Given this list of marker genes Ogdh, Dclk2, Atp7a, Plxna3, Foxg1, Atg7, Fgfr2, Scyl2, Dcx, Zmiz1, Uqcrq, Slc4a10, Disc1, here is a description of the gene set: studied in species Mus musculus Mouse Gene Set: GOBP_PYRAMIDAL_NEURON_DEVELOPMENT The progression of a pyramidal neuron from its initial formation to its mature state.